Given this list of marker genes Prnp, Homer3, Homer2, Calm1, Adora2a, Cabp1, Calm2, Fyn, Esr1, Necab2, Calm3, Homer1 (NCBI Gene Id 26556), Dnm3, Nherf1, Pick1, here is a description of the gene set: Binding to a G protein-coupled glutamate receptor (a metabotropic glutamate receptor). studied in species Mus musculus Mouse Gene Set: GOMF_G_PROTEIN_COUPLED_GLUTAMATE_RECEPTOR_BINDING